Given this list of marker genes Dlx3, Lamc1, Fgf10, Runx1, Dicer1, here is a description of the gene set: Mouse Gene Set: GOBP_HAIR_FOLLICLE_CELL_PROLIFERATION The multiplication or reproduction of hair follicle cells, resulting in the expansion of a cell population. studied in species Mus musculus